The following is a description of a gene set: Host Interactions of HIV factors Human Gene Set: REACTOME_HOST_INTERACTIONS_OF_HIV_FACTORS species: Homo sapiens, and this is the list of marker genes: PSMD14, RAE1, PACS1, BANF1, NUP153, CD8B, NUP133, PSMB5, ARF1, PSMB1, NUP98, PSMA3, NDC1, NUP107, AAAS, NUP50, UBB, PSMC6, LCK, NUP155, BTRC, APOBEC3G, PSMC4, RANGAP1, NPM1, RPS27A, SEH1L, POM121, HMGA1, NUP214, CD4, AP2B1, PSMC1, PAK2, AP2S1, NUP54, NUP188, TPR, HLA-A, ELMO1, PSMA6, PSMD2, ELOC, CCNT1, KPNA1 (NCBI Gene Id 3836), POM121C, PSMB2, AP2A1, PSMD3, PSMD7, NUP85, NUP205, PSMA4, RBX1, KPNB1, PSIP1, SKP1, CD247, SLC25A6, NUP62, SLC25A5, ADRM1, UBC, PSMA1, PSMB7, RANBP2, PSMC2, AP2M1 (adaptor related protein complex 2 subunit mu 1), PSMD6 (NCBI Gene Id 9861), RANBP1, AP1M2, SEC13, PSMD12, PSMC5, PSMA7, UBA52, NUP160, ATP6V1H, PSMB6, RAN, AP1B1, AP1S1, NUP88, CUL5, CD28, PSMB3, PSMB4, AP1M1, PSMA5, DOCK2, RCC1, PPIA, PSMD11, SEM1, SLC25A4, PSMD1, NUP58, AP2A2, AP1S2, PSMA2, PSMD13, PSMD8, NUP35 (nucleoporin 35), NUP210, NUP93, XPO1, PSMC3, AP1G1, AP1S3, CDK9, HCK, NUP37, NUP43, RAC1, FYN, NUP42, B2M, ELOB (NCBI Gene Id 91153)